Given this list of marker genes COX18, COX5A, COX6B2 (cytochrome c oxidase subunit 6B2), COA1, SCO2, COX7A1, COX7C, COX6A1, COX14, PET100, HIGD2A, PET117, COX16, COX5B, COX4I2, COX6A2, COX6C, COQ10A, SURF1, COX4I1, TACO1, HIGD1A (NCBI Gene Id 25994), COX11, PNKD (PNKD metallo-beta-lactamase domain containing), CMC1, MT-CO2, COX8C, COX7A2, TIMM21, COA3, SMIM20, MT-CO1, COX7A2L, COX6B1, COX8A, TMEM177, TMEM223, COX17, MT-CO3, COX15 (NCBI Gene Id 1355), SCO1, NDUFA4, COX20, COQ10B, RAB5IF, COX19, COX7B, COA5, here is a description of the gene set: Complex IV assembly studied in species Homo sapiens Human Gene Set: REACTOME_COMPLEX_IV_ASSEMBLY